Given this list of marker genes PRRX2, CHAF1B, MAD2L1, KLF10, S100A3, DOHH, CRABP1, COL6A3, RBMX, TSC22D1, TMEM106C, IFI27, CKAP2, ARCN1, H2AX, GMNN, VAMP5, CRIP2 (cysteine rich protein 2), EI24, EREG, PABPC4, TNRC6A, WAC, CDCA3, NSMCE4A, PTGES3, MCM4, BUB1, RANBP1, CDKN3, CDC45, FUBP1, CBX5, RACGAP1, CCK, CMC4, HMGA2, KIF22, NEK2, LUC7L3, TIMM8A, PARP1, YLPM1, H2AZ2, NQO1, PSPC1, RFC4 (NCBI Gene Id 5984), CDK1 (cyclin dependent kinase 1), SPDL1, SERF2, KANK3, CDT1, HJURP, PRC1, KIF23, HAUS3, HELB, TK1, ETFB, MCM7, SLC12A2, NAV2, PDIA3, NOP58, ST3GAL4, BTBD1, TRIM37 (tripartite motif containing 37), RFC5, SASS6, TULP4, H19, TUBB, SLC39A6, HMGB2, VCAN, BRCA2, DTL, LSM3, TOPBP1, LSM4, LAGE3, FBLN1, EPHX1, CKS1B, ALAD, GCLC, CAV1, RRM2, H2AZ1, PTMA, OGT, PERP, BRCA1, PTGER4, IPO5, CCNF, ANLN, MKI67, ANAPC5, AHCY, NASP, ANP32B, FAM13B, DLGAP5 (DLG associated protein 5), E2F8, HMGN2, STMN1, SAE1, KIF2A (kinesin family member 2A), HPF1, CBX6, TYMS, PRIM1 (DNA primase subunit 1), IFRD2, UBE2S, SMC2, XPO1, PRPF19, IGF1R, TGDS, DTYMK, LMO7, GAS6, NUCKS1, CD34, DSTN, CDH2, NIPBL, TRIP13, IDH2, RAD21, DEK, SMAD6, ORC6, RAMP3, PIMREG, ZMYND11, NUSAP1, TFDP1, NAP1L1 (NCBI Gene Id 64165), CCNB2, AMD1, CIP2A, BIRC5, SCOC, ID4, IQGAP3, HIP1R, KIF4A, PSIP1, PCLAF (NCBI Gene Id 9768), GREM2, TARDBP, HAS1, RAD51, TPGS2, TIPARP, PLK1, SNHG5, ANAPC11, FIGNL1, ILF3, CDK2, KIF11, CDCA7L, MRE11, CENPA (centromere protein A), CCNB1, MIS18BP1, PENK, RFC1, PTPRVP, CDC25C, FAS, RBBP4, KIF2C (NCBI Gene Id 11004), HNRNPR, PPP5C, CPSF2, SEMA3C, SET, COX6B2, KIF20A, PCNA, IL1R1, HMGB3, UBE2T, HMGN1, PTGIS, CES2, ASF1B, DCTPP1, MDM2, PRDX2, HDAC2, CASP8AP2 (caspase 8 associated protein 2), TIPIN, CKS2, RAD51AP1, DLX1, MCM3, SRSF2, MCM5, BANF1, SNORA57, DNPH1, CEBPZ, KITLG, CENPK, AURKA, CCNA2, GCLM (glutamate-cysteine ligase modifier subunit), HAT1, SFPQ, SMC3, ADSL, CDC6, CSE1L, GSK3A, E2F1, TRIM59, KPNA2, OTUD4, HSPD1, PRADC1, MYH11, TMPO, RCL1, SMIM11, RBL1, WWTR1, NAA10, ECT2, DNAJC9, POLA1, HNRNPC, here is a description of the gene set: from publication Markey MP, Bergseid J, Bosco EE, Stengel K, Xu H, Mayhew CN, Schwemberger SJ, Braden WA, Jiang Y, Babcock GF, Jegga AG, Aronow BJ, Reed MF, Wang JY, Knudsen ES (PMID 17452985) Functional inactivation of the retinoblastoma tumor suppressor gene product (RB) is a common event in human cancers. Classically, RB functions to constrain cellular proliferation, and loss of RB is proposed to facilitate the hyperplastic proliferation associated with tumorigenesis. To understand the repertoire of regulatory processes governed by RB, two models of RB loss were utilized to perform microarray analysis. In murine embryonic fibroblasts harboring germline loss of RB, there was a striking deregulation of gene expression, wherein distinct biological pathways were altered. Specifically, genes involved in cell cycle control and classically associated with E2F-dependent gene regulation were upregulated via RB loss. In contrast, a program of gene expression associated with immune function and response to pathogens was significantly downregulated with the loss of RB. To determine the specific influence of RB loss during a defined period and without the possibility of developmental compensation as occurs in embryonic fibroblasts, a second system was employed wherein Rb was acutely knocked out in adult fibroblasts. This model confirmed the distinct regulation of cell cycle and immune modulatory genes through RB loss. Analyses of cis-elements supported the hypothesis that the majority of those genes upregulated with RB loss are regulated via the E2F family of transcription factors. In contrast, those genes whose expression was reduced with the loss of RB harbored different promoter elements. Consistent with these analyses, we found that disruption of E2F-binding function of RB was associated with the upregulation of gene expression. In contrast, cells harboring an RB mutant protein (RB-750F) that retains E2F-binding activity, but is specifically deficient in the association with LXCXE-containing proteins, failed to upregulate these same target genes. However, downregulation of genes involved in immune function was readily observed with disruption of the LXCXE-binding function of RB. Thus, these studies demonstrate that RB plays a significant role in both the positive and negative regulations of transcriptional programs and indicate that loss of RB has distinct biological effects related to both cell cycle control and immune function. Genes up-regulated in adult fibroblasts with inactivated RB1 by Cre-lox: acute loss of function (LOF) of RB1. Human Gene Set: MARKEY_RB1_ACUTE_LOF_UP studied in species Mus musculus